Given this list of marker genes 4930519L02Rik, Gm24457, Gm6059, Gbp2b, Gm15688, Gbp3, Gm6214, Gm31306, Gm32693, Gm9415, Pdha2, Kyat3, Unc5c, Bmpr1b, Rap1gds1, Pdlim5, Gm6260, Gm25965, Gm15689, Gbp2-ps, Gm4862, Gm19184, Gm33651, Gm19080, Gm22682, 4930425O10Rik, Gm2451, Pkn2, Stpg2, Gm4863, A830019L24Rik, Gm32754, 1700001N15Rik, Mir6381, 4930590L14Rik (NCBI Gene Id 75852), Gbp5, Tspan5, Gm31211, Gm19166, Gbp2, Gm2574, Gtf2b, Gm6057 (NCBI Gene Id 606522), Gm33758, Gm2505, Gm16060, Mir7j, Gm24728, Gbp7, here is a description of the gene set: species: Mus musculus Mouse Gene Set: chr3H1